Given this list of marker genes ACTR10, PPP6R1, F5, ARF3, RAB1B, DCTN1, STX5, CSNK1D, TRAPPC5, COPG2 (COPI coat complex subunit gamma 2), TUBA4A, RAB1A, CAPZB, TUBA3D, BET1L, GOSR1, SEC22A, TMED2, AREG, KDELR2, TUBA8, COPB2, TMED7, TBC1D20, CD59 (NCBI Gene Id 966), COPE, COPG1, GBF1, SEC23A, ACTR1A, SAR1B, DCTN3, GOLGA2, COG2, TMED9, FOLR1, TUBB3, COG6, DCTN5, LMAN2, GRIA1, SCFD1, ARCN1, NAPG, SEC31B, SEC22B, TUBB2B, NAPB, USO1, TRAPPC3, TMEM115, SEC24D, DYNC1H1, PPP6R3, DCTN6, TRAPPC2, ARFGAP2, NAPA, SERPINA1, MCFD2, SEC31A (NCBI Gene Id 51424), BET1, TUBA1C, TUBB4B, ARF1, TMED10, TRAPPC6A, KDELR1, TUBB4A, TRAPPC2L, TRAPPC4 (trafficking protein particle complex subunit 4), MIA2, TUBAL3, TUBA3C, DCTN2, ANK3, ARF5, TRAPPC10, TMED3, CNIH3 (NCBI Gene Id 149111), SPTBN2, DYNLL1, TUBA3E, CAPZA3, CAPZA1, SPTBN5, CNIH2, SPTBN1, CAPZA2 (capping actin protein of muscle Z-line subunit alpha 2), COL7A1, ARFGAP1, ANK2, DYNC1LI1, TUBA4B, GOLGB1, TUBB6, ARF4, DYNC1I2, LMAN2L (lectin, mannose binding 2 like), INS, SPTAN1, TUBA1B, F8 (coagulation factor VIII), SEC13, CTSC, CTSZ, LMAN1, SEC22C, COPB1, TFG, COPA, MIA3, SEC24C, ANKRD28, PPP6C, TUBB1, CNIH1, ARFGAP3, DCTN4 (dynactin subunit 4), COG4 (NCBI Gene Id 25839), SPTB, SEC24B, SEC16A, COPZ2, PREB, COG5, SPTA1, TUBB8, SEC16B, GOSR2, GORASP1, TRAPPC1, TRAPPC9, DYNLL2, TRAPPC6B, TUBB8B, KDELR3, TUBA1A, CD55, DYNC1I1, YKT6, COG1, COG3, LMAN1L, TUBB2A, NSF, ANK1, TGFA, SEC23IP, COG7, SPTBN4, STX17, SEC24A, COG8, DYNC1LI2, COPZ1, here is a description of the gene set: species: Homo sapiens ER to Golgi Anterograde Transport Human Gene Set: REACTOME_ER_TO_GOLGI_ANTEROGRADE_TRANSPORT